Given this list of marker genes DYRK1B, DDX31, MMP19, ZFPM1, SLC22A31, SZT2, CYP8B1, ZYX, DDR2, ECH1, CATSPER2, TMEM9B, BICDL2, SERPINA1, SAXO4, ALB, SFXN2, IRF6, MAN1B1-DT, GEMIN2, PPIL2, MUC12-AS1, APOA2, DOK1, FHL1 (NCBI Gene Id 2273), RXRG, THRA, USP21, AIMP2, NMB, AZGP1, DSCAML1, FBXL6, FADS3, RLIM, here is a description of the gene set: species: Homo sapiens from publication Liu BH, Goh CH, Ooi LL, Hui KM (PMID 18332864) Low abundance transcripts specific to hepatocellular carcinoma (HCC). Human Gene Set: LIU_LIVER_CANCER Most human cancers are characterized by genetic aberrations accompanied by altered expression and function of numerous genes. Applying genome-wide, microarray gene expression analysis to identify deregulated genes in different tumour types can provide potential gene candidates as diagnostic and prognostic tools and promising targets for drug development. However, the detection of deregulated genes with low levels of expression remains a major challenge. In this study, we have designed a strategy, termed modified suppression subtractive hybridization (mSSH), to identify genes encoding rare transcripts. The strategy entails incorporating the T(7)-promoter sequence at the 5' end of the noncoding cDNA strand during first strand cDNA synthesis to generate unidirectional antisense RNA from the resultant cDNA following conventional SSH. These transcripts are subsequently analysed by Affymetrix oligonucleotide gene arrays. Here, we have used five hepatocellular carcinoma (HCC), five breast carcinoma and four nasopharyngeal carcinoma (NPC) biopsies separately as testers and their corresponding normal biopsies as drivers to enrich for low abundance tumour type-specific transcripts. The total detectable number of probe sets following mSSH was reduced almost 10-fold in comparison to those detected for the same resected tumour tissues without undergoing subtraction, thus yielding a subtraction efficacy of over 90%. Using this experimental approach, we have identified 48 HCC-specific, 45 breast carcinoma-specific, and 83 NPC-specific genes. In addition, genes were upregulated in all the three cancer types. When compared to gene-profiling data obtained without mSSH, the majority of these identified transcripts were of low abundance in the original cancer tissues. mSSH can therefore serve as a comprehensive molecular strategy for pursuing functional genomic studies of human cancers.